Given this list of marker genes Ppp2cb, Fcrl2, Krtap24-1 (keratin associated protein 24-1), Arcn1, Ppp4r1, Stradb, Pcdh9, Zfp318, Il17rd, Smim13, Tmem47, Zfp987, Cplx1, Arid4b, Strn3, Zfp143, Bcl10, Man2a1, Kctd10, Taok1, Snrk, Usp38, Fbxo28, Erbb4, Rnf24, Naa35, Pip4p2, Rilp, Zfp385a, Il13ra2, Prkaa1, Hnrnpa0, Nsg1, Arhgap20, Cpne1 (copine I), Tmem131, Zfp991, Sult1d1 (NCBI Gene Id 75979), Cdc37l1, Prpf4, Hrk, Nsd2, Thumpd2, A830018L16Rik, Dnajb11, Nop58, Polr2d, Elovl7, Slit2, Gpatch1, Nrg3, Afdn, Fbxo25, G6pc2, Rbm12b1, Zfp992, Arrdc3, Grin1os, Rsf1, Rab39, Srsf4, Zfp777, Atf7ip2, Cybrd1, here is a description of the gene set: Mouse Gene Set: MIR_351_3P species: Mus musculus from publication Chen Y, Wang X (PMID 31504780) Genes predicted to be targets of miRBase v22 microRNA mmu_miR_351_3p in miRDB v6.0 with MirTarget v4 prediction scores > 80 (high confidence targets).